Given this list of marker genes MYOC, PTPRJ (NCBI Gene Id 5795), CLASP2, VEGFA, EPB41L5, CLASP1, DLC1, VCL, BCL6, PLEKHA2, SFRP1, ITGB1BP1, ROCK2, SLK, CCR7, DMTN, PEAK1, SLC9A1, DAG1, KDR, ACER2, CDH13, S100A10, PTEN, NF1, LEF1, LIMS1, PTPRA, CCL21, EMP2, TSC1, MAP4K4, RAC1, FUT1, ITGB3, THBS1, HRG, EFEMP2, CFL1, MINK1, LDB1, CAMSAP3, CCL25, CCL28, WDPCP, GSK3B, SMAD3, AJAP1, CASK, RHOA, ONECUT2, SRC, EFNA5, DISC1, CEACAM6, CD36, SDC4, MIR92A1, TEK, EPHA1, ARHGAP6, APOD, HOXA7, CIB1, RASA1, PLPP3, GFUS (GDP-L-fucose synthase), CX3CL1, PHLDB2, RHOD, SEMA3E, NRP1, BST1, CORO1C, GPM6B, PTK2B, EPHA3, PKHD1, WNT4, FAM107A, GREM1, ACTG1, CD3E, MIR29C, MMP14, ADAM15, CDK6, LIMCH1, PLAU, FERMT1, SERPINE1, CDKN2A, BCL2, SKAP1, CSF1 (colony stimulating factor 1), MACF1, PLET1, MMP12, RIN2, DAPK3 (death associated protein kinase 3), ONECUT1, DUSP22, DDR1, RRAS, RCC2, DUSP3, NF2, JUP (NCBI Gene Id 3728), NEXMIF, POLDIP2, COL16A1, UTRN, MIR192, ACVRL1, MYF5, ABL1, THY1, JAG1, POSTN, PPM1F, FERMT2, MIR939, PIK3R1, ROCK1, PTK2, PIK3CB, TLN1, here is a description of the gene set: Human Gene Set: GOBP_REGULATION_OF_CELL_MATRIX_ADHESION Any process that modulates the frequency, rate or extent of attachment of a cell to the extracellular matrix. species: Homo sapiens